The following is a description of a gene set: Mouse Gene Set: chr10A4 species: Mus musculus, and this is the list of marker genes: Gm18903, Gm36908, Trdn, Gm25016 (predicted gene, 25016), Tpd52l1, Taar4, Gm20300, Gm10145, Gm18704, Hint3, Gm7791, Moxd1, Gm30034, Gm4777, Ncoa7, Taar8a, Smlr1, Gm30165, L3mbtl3, Gm46197, Gm6884, Ccn2, Taar3, Rspo3, Cenpw, C030006N10Rik, D830005E20Rik, Arg1, Gm36172, Gm20276, Gm18041, Nkain2, Gm8681, Gm5649, Hddc2, Rps12, Gm8793, Supt4b, Gm30676 (NCBI Gene Id 102632655), Gm24286, Gm47715, Rnf217, Taar7d, Gm30698, Gm30619, Gm48893, Slc18b1, Gm6906, Gm15136, Taar9, Mtcl3, Echdc1, 4930401C15Rik, Gm19073, Epb41l2, Gm5171, Gm23130, Gm5422, Gm232, 4930579H20Rik, Gm40617, Gm18189, Trmt11, Gm4739, Gm7333 (predicted gene 7333), Gm18507, Gm29884 (predicted gene, 29884), Taar6, Gm30534, Akap7 (A kinase anchor protein 7), A230081H15Rik (Riken cDNA A230081H15 gene), Taar7c-ps, Ptprk, 9330159F19Rik, Snora33, Enpp3, Hey2, Gm6893, Gm20304, Gm40621, Taar5, Stx7, Gm30228, Gm36543, Gm19801, Med23, Taar8c, Vnn3, Gm9996, 4930519F09Rik, Vnn1, Gm7909, Gm29571, Lama2, Taar7a, Gm6390, Tmem200a, Taar7f (trace amine-associated receptor 7F), Gm9767, Gm47939, Taar8b, Gm46218, Gm15270, Gm8767, Arhgap18, Enpp1, Gm18508, Taar1, Taar7e, Gm4780, Gm25256, 2310057J18Rik, Gm8709, Samd3, Gm18972, Taar7b, Gm2829, Gm17917, Rnf146, Themis, Taar2, Mir6905, Gm10275, Gm9824, Gm40614